The following is a description of a gene set: from publication Hale JS, Youngblood B, Latner DR, Mohammed AU, Ye L, Akondy RS, Wu T, Iyer SS, Ahmed R (PMID 23583644) studied in species Homo sapiens Genes up-regulated in CD4 SMARTA memory T cells: follicular helper (Tfh) versus Ly6c int CXCR5+. CD4 T follicular helper (Tfh) cells provide the required signals to B cells for germinal center reactions that are necessary for longlived antibody responses. However, it remains unclear whether there are CD4+ memory T cells committed to the Tfh lineage after antigen clearance. Using adoptive transfer of antigen-specific memory CD4+ subpopulations (based on CXCR5 and Ly6c expression)in the LCMV infection model, we found that there are distinct memory CD4+ T cell populations with commitment to the Tfh and Th1 lineages. Our conclusions are based on gene expression profiles, epigenetic studies and phenotypic and functional analysis. The gene expression profiles of virus-specific CD4 T cell subets at effector and memory stages is presented here. Human Gene Set: GSE43863_TFH_VS_LY6C_INT_CXCR5POS_MEMORY_CD4_TCELL_UP, and this is the list of marker genes: PTGES, BST2, RARRES2, TFRC, UAP1, PDCD10, BATF (basic leucine zipper ATF-like transcription factor), HNRNPH1, HELZ2, DNAJB9, TBX21, DYNC2H1, EDN1, FNDC3A, HSH2D, IRGM, ZNF143, TLR7, KRT222, HNRNPD, ZC3H12A, PMEPA1, CMTR2, IL6, TAGAP, CSRNP1, ATF3, CSNK2A1, XAF1, APLNR, TENT4A, CXCL10, RIF1, EEF1E1, NABP1, TREX1, CITED2, VWA5B2, TOP3A, JMY (junction mediating and regulatory protein, p53 cofactor), MCPH1, CHAC2, QPRT, LIN9, SLC25A33, AMY2A, PML, HSPA5, TMEM39A, RGS13, C1GALT1C1, MORF4L2, DTX3L, MX1, UBE2V2, CNTNAP4, SRGN (serglycin), RTP4, PPP1R15A, IL15RA, AHCYL2, SLC7A6OS, RIPK1, ASB13, LGALS9B, SEZ6L2, LARP1, USP32, TAF4 (NCBI Gene Id 6874), AOPEP, SEC24A, STAM, TFG, KLK10, IFI27, MYO1D, OTOG, PHYHD1, IRF8, ATP2A2, SBF2, BCAR3, PROM1, PCGF5, UTP6 (UTP6 small subunit processome component), ERO1A, MYBL2, KRT4, IFI44L, PPIP5K1, AVP, PKN2, SLC22A1, SERPINB9, LY75, ICAM5, EBI3, REEP2, SLC7A1, DHX15, ASCL1, EZH2, NKX2-1, LYG2, IL1RN, DDX18, CDK5R1, PLSCR1, MS4A7, MIR22HG, IFITM3, U2SURP, MDM2, GBP6, ABCG5, ASCC3, NFKBIB, SHMT1, HK2, TAP1, ICAM1, LRATD2, CCL5, AGFG1, NAMPT, IL1RAP, MOB1B, C3orf62, GABRE, ALDH1L1, TSSK6, SOCS1, SYBU, IFI44, KRT71, RAB8B, IFI35, RNF157, PGM5, MAFK, NEDD1 (NCBI Gene Id 4732), UNC79, FLVCR2, SLC25A22, FOXJ1, ARF4, ILRUN, TRIQK, DPEP1, NOTCH1, TMEM68, JAM2, NFKBIA (NCBI Gene Id 4792), MYOD1, GCNT1, CRTC2, SLFN13, NUP205, TNFSF14 (NCBI Gene Id 94566), PRXL2A, MX2, CCDC127, PARP14, VSX2, SCTR, ZZZ3, RGS1, TFDP1, DDX11, GPRC5A, SH3RF3, ZNG1B, GJC1, KDM5D, B4GALT5, SOCS3, TLE6, DOCK10, IFIT1B, AGRN, TAPT1, SLAMF1, SFT2D3, SEMA7A, BCL2L1, PFDN4, MIB1, ADAR, H2BC18, FAM178B, USP18 (NCBI Gene Id 11274), AEBP2, MKRN3, SYDE2, ISG15, OR6A2, NGEF, KDR, RPE